Given this list of marker genes Btbd7, Dctn6, Dnah7b, Zmym3, Atp5mc3 (NCBI Gene Id 277484), H2bc7, Stt3b, Gm8421, Shbg, Wdfy3, Gm12990, Fndc4, Pla2g7, Yy2, Msantd2, Pcca, Actn4, Tnfsf13, 4930551E15Rik, Pex1, Rev3l, Mis12, Gbp11, Fndc1, Ccdc34, Ube2z, Srgap3, Col1a1, Epc2, 1700072G22Rik, Speg, Gm9929, Taar4, Vmn1r-ps108, Tmem63c, Prpf40b, Fbxo44, 1700113H08Rik, Sulf1, Ptgr3, AW047730, Kcnq1, Lmod1, Krt75, Rnf145 (NCBI Gene Id 74315), Nol4, 4933408A14Rik, Gm2574, Prxl2a, Rps4x, Gamt, Tpi1, Itgb4, Sohlh2, Nckap1, Atoh7, Camk1d, Akirin1, Ccng2, Skida1, Gm12279, Cytip, Mtch1, Mphosph10 (M-phase phosphoprotein 10 (U3 small nucleolar ribonucleoprotein)), Fmr1, Eif2c5l, Mxd1, Unc93a2, Fbh1, Polr2h, Pif1, Gm16146, Mapk10, Ppp4r1, Tdp2, Dmrtc2, Amn1, Gm3945, Cdk11b, G3bp1, Trim55, Anxa9, Lims1, BC065397, Mrps28, Sik3, Slc39a6, Fer1l5 (NCBI Gene Id 639409), Uchl3, Ccdc50, Frmpd1, Fryl, Lrrn1, Mrpl48, Abhd2, Hdac5, Gm15270, Cacna2d1, Adamts9, Tbx22 (T-box 22), Yipf6, Cd300c, Hnrnpd, Glrx5, Ide, 1700034H15Rik, Gm22362, Gls2, Gba2, Gm12492, Ifi47, Gm20033, Nfyc-ps, Epc1, Enc1, Dcun1d1, Pik3ip1, Ddit4, Tff1, Frg2f1, St6gal1, Fbxo46, Pcdhb8, Rnpep, Mtrex, Rptoros, Dlgap1, Usp9y, Cbx3, Glt1d1, Echs1, Adh4, Eldr, Atxn7, Zfp266, Man2c1, Cops5, Gm26787, Pml, Dio1, Ap2m1 (NCBI Gene Id 11773), Cd86, Umad1, Ftdc1 (NCBI Gene Id 385656), Mybpc1, Tsfm, Gm17815, Tor1aip1, Ccdc170, Pcmtd2, Mir147, Atp6ap1, Cdk2, Auh, Prph2, Btnl10, Ankrd28, Tmem120a, Eif4g3, Acsl6, Tle4, Tspoap1, Kpna4, Capg, Utf1, Rnasel, Gm14163 (NCBI Gene Id 115489530), Slc41a3, Xk, Gm34583, Trp73, Gtf3c6, 4930511M06Rik, Insig2, Gm13342, Ankfy1, Tbx19, Paics, Ckap2l, Sohlh1 (spermatogenesis and oogenesis specific basic helix-loop-helix 1), Nfx1 (NCBI Gene Id 93788), Slc22a18, Chchd4, Ablim1, Sgcg, Gm2800, Ywhaz, Mgat5, Ywhab, Gm15401, Cdk1, Numb, Cops3, H2ac5-ps, Septin14, Mest, Gbp9, S100z, Tmem114 (NCBI Gene Id 74720), Ppip5k2, Gm12258, Hk2, Prpf4b, Eif2s3x, BC051077, Chdh, Zc3h7a (zinc finger CCCH type containing 7 A), Ndufa4l2, Cdv3, Bod1l, Vmn1r-ps94, Stx16, Pacs2, Ccdc38, Usp34, 1810064F22Rik, A730090N16Rik, Dnaaf10, Sh3tc2, Tex10, Plac8l1, Akap8l, Gpatch2, Gckr, Mrps27, Cttn, Shisal2b, H2-DMb1, Sgk1, Tekt2 (tektin 2), Abca8b, P2rx7, Ube2c, Tmprss5, Arsg, Tma7, Ciz1, C030037D09Rik, Rab29, Lrrc8a, Rab3a, Gm24648, Morn1, Myl4, 9430073C21Rik, Cks1b, Pmel, Atp5f1b, Zc3h13, Cep120, Mon1b, Ctnnal1, Zfp971, Nab2, Pus10, Ubn2, Sptbn5, Gm12899, Zfp395, 1810059C17Rik, Atp4a, Rufy1, Ccdc51 (NCBI Gene Id 66658), Hdac1, Ccdc30, Mlst8, Slc25a11, Supt5, Rcbtb2, Prr13, Rnf6, Gm16835, Immp2l, Arrdc4, St3gal2, Rnf44, Fnbp4, Cnksr3, Radx, Fis1, Gm5161, Mbtps2, Kalrn, Ift70a1, Coq10a, Gapdh, Fbln2, Mcf2, Sars1, Tanc1, Atg2a, Jmy, Gm3617, Tmem70 (NCBI Gene Id 70397), Acacb, Serhl, Ppp2r5a, Gm10309, Gm23231, Gm15589, Acly, Oit3, Tbx3os1 (NCBI Gene Id 105242420), Slc25a25, Srpk2, Gm26670, Msh4, Rev1, Cflar (CASP8 and FADD-like apoptosis regulator), Mtmr3, Mir1981, Tmem161b, A930012O16Rik, Lrp8os2, Boc, Zfp574, Slc4a3, Rnf5, Cryzl1, Snord59a, Zfp512b, Ankhd1, Hoxd3, Thap12, Elmo2, Slc35a2, Trpc4ap, Wdr90, Cbln4, H2bc15, 4930431L21Rik, 1700018A04Rik, Cdc14a, Tsc1, Psip1, Wipi1, Gata5os, Kdm2b, Brd2 (bromodomain containing 2), Mir1960, 1600010M07Rik, Slc25a5, Rnf113a1, Pwwp2a, Vsig1 (NCBI Gene Id 78789), Atp8b2, Ruvbl2, Aars2, Cst9, Dbndd1, Rab11b, 4930401G09Rik, Arhgef2, Aox3, Chd8, B230217C12Rik, Gas2l3, Odc1, Tsc22d3, Adam32, Gm12687, Virma (NCBI Gene Id 66185), Ppp3ca, Tmbim6, Gm2420, Trdj1, Med14, Ttll12, Aimp1, H3c7, Mdm4, Hnmt, Tfec, Tln1, Mir199a-2, Zfp663, Traj2, Syne2, Malat1, H1f0, Intu, Tbccd1, Snx33, Mir181c, Enpp5, Ddx19b, Mir1291, Dmrtb1, Lsm11, Gfra3, Srf, Fthl17-ps3, 1700041G16Rik (NCBI Gene Id 73299), Sag (S-antigen, retina and pineal gland (arrestin)), Csnk2a1, Gm22973, Hvcn1, Flad1, Rnf7, Mospd1, Tapbp, H1f1, Rfxank, Tardbp, Pbdc1, Iqsec2 (NCBI Gene Id 434870), Kptn, Dedd, H2bw2, Tfe3, Naa20, Usp4, Rpl36a, Sipa1l1, Prpsap1, 2010110K18Rik, Psma3, Lrrc8b, Slmap, Rgs16, Zfp330, Rab4b, Cggbp1, Mapkbp1, Coasy, Fam107b, Znrf3, Atp6v1g2, Med9, Bmpr1a (NCBI Gene Id 68748), Dst, Glis3, Gm572, Zmiz2, Cdan1, Kat6b, Scrib, Ube2k, Pgap1, Gm14221, Maf1, Magea14, Eno1, Eef2, Spag9, Eif2ak3, 2610035D17Rik, Cic, Tyro3, Gm13752, Dmxl1, Sinhcaf, Gfod2, Gsx2, Glt8d1, Arf5, Mageb18, Hdgfl2, Ly6g6c, Iqank1, Aqp7, Zfp691, Frmd5, Nubpl, Isoc2b, Gm16150, 4921511C10Rik, Nos1ap, Supt6, Gm16080, Septin12, Szt2, Cpsf1, Stra6, A830035A12Rik, Ndst3, Hmgn5, Gm6257, Nr3c2, Gm8241, Gm25852, Tgtp1, Larp4b, Gm16833, Entrep2, Chd2, Rab5b, Gm10544, Tcf4, Col28a1, Psma7, Tlr3, Trdd2, Gbp6, Lonrf3, Mir203, Anxa2, Parp3, Myh13, Mad1l1, Gm12351, Gm28513, Ttf1, 8030474K03Rik, Cpd, Evi5l, Mettl8, Gm15032, Plec, Unc45b, Rad51ap1, Aunip, Hesx1, Tmpo, Lrp2bp, Dlat, Hsd11b1, Gm43001, Shroom4 (NCBI Gene Id 208431), Got1, Hectd2os, Msmo1, Slc25a23, Gbp8, Ep400, Gin1, Zeb2os, Rnf146, Lyrm7os, Oplah, Vdr, Nkrf, Ctdsp1, 5830462I19Rik, Rgp1 (NCBI Gene Id 68706), Rbpj, Psmf1, Stx1a, Pola1, Zfp407, D930032P07Rik, Pls3, Dthd1, Il17rb, Vps33a, Usp16, Gm11747 (NCBI Gene Id 100126224), Kbtbd2, F11r, Exoc3l, Mrpl21, Ccsap, Ubap2, Atp11c, Cct5, Mir6390 (NCBI Gene Id 102465207), Lpcat1, Mxra7, Arhgap45, Tcim, Lpo, Rpn2, Slfnlnc, Tex13d, Csnk2b, Ndufa1, Ythdf2, Fam72a, Pecr, Tbc1d10b, Ripk4, Magi1, Nphp3, Gpt2, Myh10, Slc2a12, Itgb2, Mir8110, Slc9a9, Phf8, Slc1a5 (NCBI Gene Id 269874), Mt1, Gm26176, Zfp287, Timm10, 2500004C02Rik, Ube2g1, Gm22979, Cited1, Fmnl2, Fam221a, Rbm26, Ap1g2, Xrn2, Dcbld2, Gpsm1, Ube3d, Mir378b, Dcaf8l, Mir704, Gm13787 (predicted gene 13787), Wsb2, Defb19, Srrd, Mir17, 5530601H04Rik, Trrap, Spmip2, Gm15527, Cdk20, Ccnf, Bcas3, Gm371, Ap1s2, Gm11753, Gm24171, Gm18443, Sirt2, Slc27a6, Nfe2l1, Csrp1, Rapgef3, Kel, Kcna6, Rbms3, Serpina5, Gm12795, Chchd1 (coiled-coil-helix-coiled-coil-helix domain containing 1), Rif1, Etd, 9430097D07Rik, Cnot6l, H2-T24, Ccdc28b, Serpina3d-ps, Cyp1b1, Gm24610, Otub1, E330011M16Rik, H2ac21, 6530411M01Rik, Tle1, Akap9, Gp1bb, Prrx2, Ube2f, Gm4035, Bloc1s4, Gm16305, Psmb6, Stk11, Gripap1, Clk1, Anp32e, Pigs, Armc2, Ap2a1, Setd3, Bub3, Gas7, Sobp, Nlrc5, Dnajb11, Sesn2, Yy1, Gm8624, Six3, Krtap31-3, Ccdc12, E330012B07Rik (RIKEN cDNA E330012B07 gene), 4930429D17Rik, Itpk1, Erg, Rps27, Sort1, Specc1l, Hm629797, B230398E01Rik, Plekhs1, Hbp1 (high mobility group box transcription factor 1), Vcf2, Rassf2, Blvrb, Fbxo33, Gpi1, D030018L15Rik, Gm25881, Gm26766, Sdhaf3, Irf6, Gm30613, Niban3, Psme4, Nfkbia, Ush1c, Ggnbp2, Cct8, Tro, Ddx39b, Derl2, Col24a1, Tspan9, Ank1, Cad, Lasp1, Rab35, Nhlh1, Pam, Gm14340, Nadk2, Gm22335, Sar1b (NCBI Gene Id 72945), Rabac1, Trim80, Enpp2, Zbtb11, Ric1, Mir375, Asb9, Ahctf1, Mycs, Tubb5, Dnaja1, Kmt5a, 2410002F23Rik, Gm24070, Rce1, 9130019P16Rik, Gm11714, Rbm39, Dao, Gsk3b, Hdc, Gm25588, Gm24032, Cks2, Tle3, Defb45, Srgap2, Fat1, Gm2479 (predicted gene 2479), Col4a3, P2ry13, Ezh2, Inpp5b, Khdrbs2, Cimip4, Saxo1os, D430041D05Rik (NCBI Gene Id 77092), Gm18821, Acap1, Gm12495, Gm9828, Orc4, Cltc, Calm3, 1700069L16Rik, Gm13136, Nckap5l, Atad5, Mcm9, Myzap, Card14, Ppp1r2-ps4, Syt7 (NCBI Gene Id 78663), Rab21, Gsta3, Rnf214, Sp2, Hpn, Mib2, Stk4, Mknk2, Gm33280, Gm22791, Stx5a, 1700123M08Rik, Aacs, Smyd1, Gm16291, Uckl1os, Nab1, Src, Rhobtb1, Gsta4, Zeb2, Aopep, Wipf3 (WAS/WASL interacting protein family, member 3, NCBI Gene Id 330319), Ddx52, Gm525, Cdk12, Sorcs2, Cish, Nsmaf, Efcab2, Mff, Klrb1a, Rnf167, Eif3h, Uckl1 (NCBI Gene Id 68556), Gaa, Rnf26, Gm24172, Orai3, BC039966, Rufy2, Vwa3b, Ogt, Mapkapk3, Arl6, Sfpq, Crtc3, Trgv5, Septin3, Mir6405, Serpinb2, Morf4l1, Gm11696, Tnpo2, Mxd3, Dock11, Mir17hg, Gm6712, Trerf1, Hs6st1, Ube3c, Adam19, Ice1, Axdnd1 (axonemal dynein light chain domain containing 1), Gbp4, Gm11405, Tbx20, Phip, Nrp2, Atxn1, Gm17059 (NCBI Gene Id 102640356), Macf1, Atg9a, H3c1, Aldh1a1, Gm7457, 4930519F09Rik, Foxn3, Ak2, Lypd4, Bahd1, Smarca2, Nsmce4a, Galk1, Htr2b, Adgrg1 (NCBI Gene Id 56037), Magea13, Bmal1, Nup98, Padi2, Gm16506 (NCBI Gene Id 673132), Abhd12b, Mcu, Frg1, Rps3a2 (ribosomal protein S3A2), Filip1l, Magec2, Kif21a, Cep128, Golm2, Pemt, Hacd2, Ripor2, Sema4a, Mtmr14, Bola2, Dffb, Tcerg1, Kif1a, Gm11551, N4bp2os, Fem1c, Plekhg5, Fgf9 (NCBI Gene Id 252883), Abcc2, Selenoi, Vps51, Rpgrip1, Zfyve19 (NCBI Gene Id 72008), Bricd5, Mettl26, Chordc1, Tmc7, Cript, Kcnk2, Mrps5, Midn, Dnajc25, Iqgap1, Ccnd3, Tsr1, Itsn1, H2ac6, Tmem250, Mir653, Gm15764, Actl11, Il6st, Calm2, Gm27011, Cma1, Gm26273, Pwwp3b, Get4, Shtn1, Calcrl, Mir8095, Pik3c2b, Spen, Nipsnap3a, Ophn1, F8, Nr4a2, Traj3, Tjp1, Gm11613, Dnajc22, Lonp2, Slc10a6, Arid4a, Fam149a, Gm15638, Ankrd54, Atcayos, Bclaf3, Phf3, Gngt2, Mir6358, Ppcs, 1110006O24Rik, Clint1, A930024E05Rik, Rnf149, 9030616G12Rik, Zfp951, Fam78b, Mei1, Rgs22, Clrn1, Ano7, Tcf3, Wdr44, Snrpa1 (small nuclear ribonucleoprotein polypeptide A'), Cracr2a, Hnrnpk, Plxna3, Spata17, Iqcd, Txnrd1, Mcm3, Tpx2, Dlgap4, Pkn2, Nfia, B3galnt1, Gm23622, Clspn, Gm15410, H2bc8, Rhbdf2, Plxnb2, Ambp, Mrpl1, Smg8, Suco, Pgd, Klf13, Nr1h5, Kansl1l, Zfp12 (NCBI Gene Id 231866), Lats2, Ct55, Tns1, Cspp1, Ppm1m, Gm11718, Gm12361, Gm15010, Fbxo36, Las1l (NCBI Gene Id 76130), Rras2, Ivd, Sephs1, Helb, B3galnt2, Trpc5os, Myom3, Hnrnpa1, Tceanc, Lgals7, Myef2, Usp10, Esam (NCBI Gene Id 69524), Yipf5, Fmc1, Ptpn9, Mbd5, Hcfc1, Ggta1, Phax, Gm13063, Npr1, Msl3, 3110056K07Rik, Gm7593, Atraid, Gm20501, Setd5, Paip2b, Stpg2, Hmgcs1 (NCBI Gene Id 208715), Twf1, Pgghg, Gm10829 (NCBI Gene Id 108168746), Ddah1, Gm23834, Slc23a4, Myl9, Aldh1a3 (aldehyde dehydrogenase family 1, subfamily A3), Lnx1, Fundc2b, Idi1-ps5 (isopentenyl-diphosphate delta isomerase, pseudogene 5), G430095P16Rik, 4930571N24Rik, Cd93, Sesn1, H2ac7, Stra8, Cadm1, 2700062C07Rik, Rgs9bp (regulator of G-protein signalling 9 binding protein), Pold4, P2rx3, Fxyd3, Vmn1r1, Ttc6, Slc13a2os, Dhcr7, Gm11870, Kin, Arhgap32, Usp21, Tex19.2, Coq8a, Rec8, Clip2, Brca2, Ephx4, Necab1, Srgap1, Ppm1b, Gm23497, Gm26049, Gstcd, Tet2, Cfap52 (cilia and flagella associated protein 52), Pknox1, Gjc3, Gm6543, Gpr157, St3gal6, Pigh, Gar1, Pop1, Atp6ap2, B3glct, Slc44a1, Stt3a (NCBI Gene Id 16430), Rab11fip3, Ube2q2, Lmnb1, Il1a, Btf3l4, Arl8a, Mtarc2, Sgf29, 4933440M02Rik, 6430710C18Rik, Cpeb3, Pasd1, Cox7b2, Syncrip, Zfp120, Rbm47, Mbnl1, Saxo4, Sptan1, Ston1, Epn1, Rnaseh2a, Sema4d, Gm24134, Trpv5, Shb, Nenf, Qrich1, Wdr4, Akap11, Ank3, Paqr3, Gm14634, Cep295nl, Traj23, Gm6142, Abcc6, Nsd3, Siah2, Ppt2, Slc16a1, Pnldc1, Dcaf15, Mirlet7c-2, Ran, Ipo11, Fundc2, Tbx3, Selplg, Micu1, Bahcc1 (NCBI Gene Id 268515), Gm13214, Kdm5c, Dnajc13, Gm15348, Rhoh, Cytl1, Gm5270, Onecut1, Lin9, Tbc1d14, Atp6v1b2, Npc1, Ubl3, Il9, Mtus2, Pak2, Gpr179, Mmgt2, Rnf10, Vasp, Polr3g, H2az1, Tbc1d25, Gale, Zbtb32, 4930405H06Rik, Trp53bp1, Dgkeos, Ssbp3, Clcn2, 0610043K17Rik, Miip, Sema6d, Tnfaip3, Obi1, Mast4, AU020206, Nr1h3, Hmbox1 (NCBI Gene Id 219150), Zfp809, Ssx2ip, Plekhg2, Snord91a, 1600014C10Rik, Gtpbp1, Diras1, Slc25a45, H2ac8, Rap2c, Tstd2, Lrch3, Snapc3, Mta3, Rnu11, Gm13179, Cited2, Nfkb1, Borcs8, 1810008I18Rik, Rab11fip4, Mttp, Hcrtr2, Meis2, 2610307P16Rik, Ighmbp2, Tmod1, Ino80, Def8, Akap1, Actr3, Ankrd16, Mymk, Zfp207, Gm8449, 1700001D01Rik, Dnmt3b, Hyou1, Gm13588, Ung, Septin6, Ppp3cb, Myb, Tmem156, Mir6244, Cyp11a1, Abi3, Kcnk6, Zfp184, Yrdc (NCBI Gene Id 230734), Gm10075, Gm13668, Rad23a, Ktn1, Kif22 (NCBI Gene Id 97392), Sult1a1, Gm12530, Rras, Dab1 (NCBI Gene Id 545665), Hnrnpl, Zfp386, Prkab1, Gm12925, Slco1a8, Vgll4, Gm650, Tmbim7, Atp1b3, Trpm7, Dennd11, Bcas1, Gm6057 (predicted gene 6057), Rps12-ps7, Llgl1, Nupr2, Chst9, Rdm1, Irak2, Fam83g, Rapgef4os2, Acp7, Ffar2, Igkv2-137, Grwd1, Chp1, Gpatch8, Ankrd44, Kpnb1, Mcur1 (NCBI Gene Id 76137), Mir3473b, Ciapin1, Gm14251, Foxj3, Gca, Tmem43, Rnf20, Krit1, Dhx40, Gm14514, Stimate, Zcchc14, 3010003L21Rik, Ezr, Ppm1n, Nadsyn1, Nkapl, Gls, Syn3, Usp19, Esd, Ncor1, Zfp750, Snora69, Gm35106, Tspan5, C330018A13Rik, Gapvd1, Fam219a, Yap1, Lrrc75a, 1700039M10Rik, Slco2b1, Gm12344, 1110020A21Rik, C330013E15Rik, Wt1, Glrx2, Fam186a, Abcd2, Nlk, Grep1 (glycine rich extracellular protein 1), Racgap1, 8430423G03Rik (RIKEN cDNA 8430423G03 gene), Pcnx2, Gm17768, Akap7, Septin7, Tfap2a, Txndc11, Ecpas, Gm14023, Map2k3, Sharpin, Ankrd27, Faf2, Ccdc88a (NCBI Gene Id 77927), H3c11, Mir7655, Frmd8os, Rora, Mink1, Ap5s1, Gata4, Gtf2i, Iqca1l, Ankzf1, H2bc22, Gm15915, Eri3, Lhx4, Pan2, 1600023N17Rik, Micall2, Trim2, Ube4b, Kifap3, Platr4, Cbfa2t2, Igf2bp2, Rnf212, Dolpp1, Wdr5, Pak1ip1 (NCBI Gene Id 76026), Bend6, H2bc3, Mcee, Mir181d, Slc38a3, Relt, Cfap20, Acot11, Arl6ip5, Cfap54, Smdt1, Tctn1, 2310022A10Rik, Mir1893, Appl2, Piga, Scarb1, Krtap31-1, P2ry14, Cdc25c, Dnai1, Heatr5a, Dpf3, Vma21, Ppat, 1700110C19Rik, Sppl3, 5730522E02Rik, Mppe1, 2610001A08Rik, Taf7l, Ap3m2, Nfatc2ip, Mir466f-4, Castor2, Taf7, Fbxo16, Mettl27, Aida, Bcl2l13, Smarcal1, Col18a1 (NCBI Gene Id 12822), Aebp2, Myh14, 2310014F06Rik, Gm11457, Usp5, Tpcn1, Brd7, Gm10782, Bcar3, 1700073E17Rik, Gm26011, Mro, Bbox1, Lalba, Mgat4f, Cdkn2d, Map7, Slc39a3, Rcbtb1, Nuak2, Hsp90b1, Map2k6, Cep57l1, Cracd, Nosip, Cul4b, Gm23754, 1110004F10Rik, Agmo, Tgm2, Gm15627, Xpo6, Slc25a15, Xpr1, Ugcg, Gm14569 (NCBI Gene Id 101055983), Nherf1, C630043F03Rik, Smc4, Adnp, Gm11378, Mtmr7, Snx7, Vcp, Gm16701, Zfand1, Mfge8, Pbx4, Il17d, Gm11475, Dnm3, Tia1, Tmem147, Srrm3, Pramel13 (NCBI Gene Id 97182), Prdm9, Slc11a1, Bbs9, Gm20045, Plk2, Tmem231, Spryd4, Garin3 (golgi associated RAB2 interactor 3), Slc13a4, Guf1, Myh1, Dbr1, Slc12a8, D17H6S53E, Gm26079, Gbp10, Ndufb2, Csf1r (colony stimulating factor 1 receptor), Sccpdh, Scarb2, Setx, Ubb, AB124611, Msi2, Ppp2r3a, Cnga1, Rrbp1, Pde1a, Ccnk, Tnik, Epo, Ptf1a, Mir5101, Zwilch, Osm, Hhat, Gm17782, A130050O07Rik, Morf4l2, Mrpl35, Prkaca, Srr, Dip2b, Neudnr, Mast2, Zfp442, Fbxo40, Scrn1, Rsph14, Gm9081, Ptgir, Phc2, Hif1a, Skap1, Zfp106, Fbxo42, Prmt9, Zfp61, Dync1h1, Srpk1, Capn2, Sipa1l3, Lsm10, Atf6, Gm29538 (NCBI Gene Id 102636980), B4galt3, Samhd1, Gpx5, 2810403D21Rik, B4gat1, Pabpn1, Anapc13, Tuba1b, Zfp599, Plekha6, A430105J06Rik, Mir99ahg, Unc79, Gm12156, Mir6992, Sergef, Zfp7, AI506816, Fam199x, Sik2, Ttc32, E130114P18Rik, Dhx58os, Ptgfr, Gm22676, Gm16228, Ubxn2a, Zfp536, BC002059, 1810034E14Rik, Clk2, Jmjd1c, Srsf1, Tulp2, Thumpd3, H3c8, Slc6a14, Rbm45, Spmap1, Cep19, Acta2, Sspn, Gm19391, Tnfaip6, Trip12 (NCBI Gene Id 73751), Cldn20, Pkm, Sys1, Gm34767, Ltbp3, Gm11992, Mir582, Slc6a12, Hip1, Tmed9, Unc45bos, Amhr2, Snord3a, Thra, Klf8, Bmt2, Vmn2r87, Vps41, Kcnc4, Ell3, Rpl7a, Eng, Tcaim, Gm4779, Mrc1, Sorl1, Top1, Smim24, Fsip2l, Gm9785, Dmrta1, Smim19, Bach2, Gm10655 (predicted gene 10655), Ncoa2, Rtcb, Gm13310, 9530002B09Rik, Eppin, Nme7, Srcap, Igf2r, Cdk19, Calhm1, Gm28809, Sirt7, Plppr5, Fdft1 (NCBI Gene Id 14137), Gm15528, Lamc2, Gja6, Pax4, Prtn3, Cdk17, Bcat1, Rubcnl, Gm11413 (predicted gene 11413), 4930526L06Rik, Epha7, Dmrt1, Gm17541, Npepps, Zswim4, Usp11, Foxq1, Runx1t1, Rexo2, Ptcd2, Paxip1, Cep70, Samd4, Actl6a, Slc25a53, Ints3, Timp3, Ash2l, Calr4, Upb1, Cdc123, Dusp15, Arid1a, Nags, 4933427D14Rik, Cct8l1, Apol7a, Gm24920, Gm9752, Spdl1, Podxl2, Itgb8, Rusf1, Stag2, Phkg1, Pttg1ip, Gm7854, Gnb2, Fyn, Shc1, Terf1, Rfwd3, Dpysl5, Natd1, Rasal2, Cep97, Arpc1a, Ros1, Mir5127 (NCBI Gene Id 100628596), Spart, 2900089D17Rik, Trim67, Gm13879, Tspyl5, H2bc26, Ptpa, Gpx7 (glutathione peroxidase 7), Tnfsf10, BC028471, Spp1, 9630028B13Rik, Aph1a, Acss2, Prelid2, Phf12, Osbpl1a, Yeats2, H3c3, Tfdp2, Eya2, Ube2d2b, Dnm3os, Pax1dt, Mir6541, Gm16277, Cdc25a (NCBI Gene Id 52289), Fto, Bnip3l (BCL2/adenovirus E1B interacting protein 3-like), Gm22880, Esrp1 (epithelial splicing regulatory protein 1), Satb1, Trak1, Zzz3, Btf3-ps7, Ar, Gm6211, 3300002I08Rik, Lpin2, Gm12020, Gabrr2, Fndc3a, Ccnl1, Zfp260, Atg3, Gpank1, Elavl4, Mpp7, Hoxb4, Lclat1, Kat2a, Haus6, Mtf2, Cbx5, Tspyl1, Zfand4, Scmh1, Gm16063, Cdca8, Pigo, Rad17, Slc25a22, Apobec3, Coro7, Asb7, Ppfibp2, Luzp1, Rbm43, Cyth2, Brsk1, H3c13, Mylk3, Gsap, Med1, Blvra, Lrp10, Lgals3, Pde4d, Epas1, Ucp2, Tbc1d10a, 6430571L13Rik, 1700040K01Rik, Iba57, Gm15889, Zscan5b, Gm3510, Phkb, Ccm2, Atp6v1h, Rbm19, Slc25a12, Agpat1, Agpat3, B230216N24Rik, Memo1, Gm12091, Fam91a1, Gm15545, N4bp2, Kmt5c, Scgn, Nav2, Magea10, Dusp6, Rbm25, Pds5b, Qars1, Ajuba, Tbck, Ctso (cathepsin O), Coro1b, Nup54, Gm4221, Slc35e4, Rilpl2, Sod3, Mup5, Tecpr1, Slc9a2, Sh2d3c, Tmem169, Mettl24, Pls1, Larp1b, Acsm3, Cx3cl1, H2-Oa, Ttc41, Kcnab2, Hspb9, Meiosin, Bcl9, Stau1 (NCBI Gene Id 99402), Tkt, Xpnpep1, St3gal5, Cnot11, Map4k4, Arl8b, Rbm10, Gm17491, Parl, Atp8a1, Kcnab3, Kmt5b, H2ac15, Ing5, Rhox8, H2ac19, Gm13583, Mnd1, Rigi, Stim2, E230013L22Rik, Anapc5, here is a description of the gene set: Mouse Gene Set: DMRT1_TARGET_GENES from publication Yevshin I, Sharipov R, Kolmykov S, Kondrakhin Y, Kolpakov F (PMID 30445619) species: Mus musculus Genes containing one or more binding sites for (Dmrt1) in their promoter regions (TSS -1000,+100 bp) as identified by GTRD version 20.06 ChIP-seq harmonization.